The following is a description of a gene set: Human Gene Set: GOBP_PARENTAL_BEHAVIOR A reproductive behavior in which a parent cares for and rears offspring. species: Homo sapiens, and this is the list of marker genes: OPRK1, FEV, PTEN, NPAS1, CREBRF, DBH, BRINP1, AVP, ZFY, AVPR1A, DRD1, NR3C1, MBD2, HCN1 (hyperpolarization activated cyclic nucleotide gated potassium channel 1), GAL, OXT